Given this list of marker genes PRMT6, TLNRD1, MINDY2, USP4, MITF, SPATA6, ATG7, TTC7B, CAMK2N1, RCN2, DENND4C, HSPB1, C11orf58, HAPSTR1, GPR108, KRT28, CWC22, CPEB4, KCNAB1, WDR47, H2BC13, PYROXD1, PTRH1, COPS7B, ITGAM, EDEM3, LARP4, VTI1A, NAT9, GATB, RILPL1, MMADHC, ZNF862, CD36, PCDHGC4 (protocadherin gamma subfamily C, 4), MMP19, CXorf38, LAYN, PDPR, TSC1, PDLIM5, SMAP1 (NCBI Gene Id 648324), NF1, RRAGD, RNF19B, LTBP3, MAGED1, RNLS, FOXO3, DUSP3, KLHL13, PEDS1, RNF44 (ring finger protein 44), HYOU1, GRID2IP, FJX1, ZFYVE9, TRAPPC6B, TMOD1, RAD9B, FAM210A (family with sequence similarity 210 member A), PLA2G2D, PLBD2, MAN2C1, LAP3, GTF2H3, HSD17B6, PIGC, AGPAT3, GABARAPL2 (NCBI Gene Id 90769), UBXN7 (UBX domain protein 7), TRAF5, C19orf33, RNMT, UBTD1, ATP10D, ZFAND2A, PDF, MAOA, HAUS2, DDA1, OLR1, MPZL1, MFSD12, RPS26, HEATR5B, ZFAND6 (zinc finger AN1-type containing 6), CALU (calumenin), BTBD6, CHMP1B, ARHGAP35, TMEM37, C16orf87, DDX54, ST18 (NCBI Gene Id 9705), LMAN2, CCDC186, CHCHD3, PIK3CA, MTM1, PTGR3, GPHN, SLCO2B1, ETFDH, RCBTB1, WDR89, ACOT9, SLC16A14, FBXL16, SERPINB6, SYS1, DAP, C5orf24, FYTTD1, PRKAB2, MTMR10, CLCN3, RIN2, RAB5A, ACSS1, DCTN1 (dynactin subunit 1), C3orf33, FBXL20, ATP6AP1, PEX11G, LIMS2, PYCR3, NDUFS5, LPCAT1 (lysophosphatidylcholine acyltransferase 1), ECE2, LETM1, MTURN, GOLM1, KBTBD13, AP2A2, TARBP2, ASL, TENM1, SYDE2, ELOVL3, SLC25A1, TGDS, BRWD1, SYK, TMEM33, FAM53C, VCL, YIPF6, TMEM11, RETSAT, IGF2BP3, STXBP5, ATIC, DYNC1LI1, PAM, CCNG1, VPS53, YPEL4, LDLRAP1, GLRB, NAA35, PTGR1, OXCT1, RABAC1, SEL1L (NCBI Gene Id 6400), ESPN (espin), AGPAT4, TMEM208, NIPSNAP3A, LDHA, AP3M1, HMG20B (high mobility group 20B), CASP9, SECISBP2L, UBE2G2, NAPA, TMEM184C, LIMK1, ADSS2, RAB10, CAVIN1, NACC2 (NACC family member 2), HOMER3, CRIM1, HBEGF, EPHX1, SELENBP1, CYTH3, ATP6V0D2, ESF1, FMNL2, UXS1, DIP2A, VPS45, NDFIP2, CNIH1, AKR1A1, RRP12, PDGFA, TIMM8A, here is a description of the gene set: IL-10 or IL-6 stimulation of control 129xC57BL/6 murine bone marrow derived macrophages in the presence of LPS. We used microarrays to detail the global programme of gene expression changes in response to IL-6 or IL-10 stimulation in the presence of lipopolysaccharide. BMDMs were isolated from control, IL-6-/-, and IL-10-/- mice on a 129XBL/6 mixed background mice and differentiated in the presence of CSF-1 for 6-7 days. Cells were scraped and plated in 6 well plates at 2x10e6/well. Cells were washed with complete DMEM and rested for 1-2 hr before stimulation with combinations of IL-10 (10 ng/ml), IL-6 (2 ng/ml) or LPS (100 ng/ml) for 45 min or 180 mins. Complete biological replicates were performed. species: Homo sapiens Genes up-regulated in bone marrow-derived macrophages: untreated (0 min) versus LPS (180 min). Human Gene Set: GSE5589_UNSTIM_VS_180MIN_LPS_STIM_MACROPHAGE_UP from publication El Kasmi KC, Holst J, Coffre M, Mielke L, de Pauw A, Lhocine N, Smith AM, Rutschman R, Kaushal D, Shen Y, Suda T, Donnelly RP, Myers MG Jr, Alexander W, Vignali DA, Watowich SS, Ernst M, Hilton DJ, Murray PJ (PMID 17114459)